The following is a description of a gene set: species: Homo sapiens IRF3 mediated activation of type 1 IFN Human Gene Set: REACTOME_IRF3_MEDIATED_ACTIVATION_OF_TYPE_1_IFN, and this is the list of marker genes: TBK1, NLRP4, DTX4, ZBP1, IRF3